Given this list of marker genes POMT1, GMNN, MYCN, TSC2, LMNA, NDE1, MT-ND6, SCN4A, ADAMTS13, BMPER, DPM2, LRP12, SFTPC, MTR, SNRPN, KRT16, GNAI3 (G protein subunit alpha i3), NAGS, VPS33A, SBDS, NDUFA8, PPP1R21, MT-TN, HACE1, IL6ST, CDT1, SLC52A3, PUF60, MT-TK, SYT2, XPNPEP2, CDC6, UBE3B, WDR45B, EP300, KCNA1, MMACHC, GBA1, KRT17, SLC31A1, KAT6A (lysine acetyltransferase 6A), LGI4, SRP54, UBA1, ETFA, BTD, ASAH1, MT-TV, ETFDH, TSC1, B3GALT6, ABCC6, SUCLG1, MT-ND3, ORC6, LIN28B, HMGCR, SFTPB, SLC18A3, SURF1, COL25A1, TK2, ATP5F1E, SLC2A10, MEGF10, NDUFB11, TFAM, CHAT, DMPK, ATP1A2, TUBB4A, ENPP1, MT-ATP6, SLC12A3, COL2A1, SLC35A1, ACTA1, RNF13 (NCBI Gene Id 11342), LAMB3, STAT5B, LAMA3, ATP5F1D, CNTNAP1, GAA, TP73, MT-ATP8, HLCS, GALC, ALG12 (ALG12 alpha-1,6-mannosyltransferase), CHRNE, CLCNKB, CDC45, KATNB1, AGRN, RRM2B, FGFR1 (NCBI Gene Id 84151), LONP1, CREBBP, RUNX2, RPS26, PMM2, CSF2RB, CSF2RA, AIFM1, SLC25A3, PSAP, FBP1, EPHB4, MGAT2 (NCBI Gene Id 4247), TRPV6, SOX9, PHOX2B, FOXP3, KRT6B, ITGA3, MT-ND2, SDHA, ATP6V1B2, LMO1, SLC5A7, LIFR, MYBPC3, TRMU, LYRM4, OTX2, RAP1GDS1, NEMF, MT-TW, LAMB2, MT-ND1, DYNC2LI1, CLPB, ACADVL, ERGIC1, ORC1 (NCBI Gene Id 4998), YARS2, GOSR2, SLC1A3, KRT6A, RPS28, GATA6, MT-ND5, EOMES, SERPING1, COL13A1, IL1RN, EFTUD2, MT-TL1, PURA, DPM1, COX7B, MMUT, MYO9A, ADCY6 (adenylate cyclase 6), SLC22A5, DNAJC21, REEP1, EDN1, ADNP, SDCCAG8, MT-ND4, SIK1, FGFR2 (NCBI Gene Id 2263), SETBP1, NKX2-1, PRRX1, RELN, STT3B, NUP214, ERF, ZFPM2, ATP1A3, DNAAF3, SNAP25, TBC1D24, ATPAF2, IFIH1, EDA, COLQ, FOXF1, IDH1, SSR4, CACNA1A, MPC1, NGLY1, FGFR3, TPI1, COQ7, USP9X, TRAK1, ACADS, ATP5MK, MMAB, ALMS1, MOGS, DHX16, FAM20C, ATP5F1A, ABCA3, BAP1, SCYL2, HCCS, IFT81, SLC25A1, MAPT, IFNG, ZIC3, ETFB, ALK, MMAA, ORC4, MTM1, SERPINH1, MPV17, IFT52, BOLA3, PLCB4, MYT1L, SCO2, TRIP11, LAMC2, MT-TE, PRKAG2, KLHL7, VAMP1, here is a description of the gene set: studied in species Homo sapiens Respiratory distress is objectively observable as the physical or emotional consequences from the experience of dyspnea. The physical presentation of respiratory distress is generally referred to as labored breathing, while the sensation of respiratory distress is called shortness of breath or dyspnea. Human Gene Set: HP_RESPIRATORY_DISTRESS Respiratory distress